Given this list of marker genes TRRAP, CFDP1, ANP32E, EP400, RUVBL1, ING3, BRD8, KAT5, RUVBL2, SRCAP, DMAP1, ACTR6, ZNHIT1, here is a description of the gene set: A multisubunit protein complex that is involved in chromatin remodeling. It is required for the incorporation of the histone variant H2AZ into chromatin. In S. cerevisiae, the complex contains Swr1p, a Swi2/Snf2-related ATPase, and 12 additional subunits. studied in species Homo sapiens Human Gene Set: GOCC_SWR1_COMPLEX